The following is a description of a gene set: species: Homo sapiens Tarsal synostosis Human Gene Set: HP_TARSAL_SYNOSTOSIS Synostosis (bony fusion) involving one or more bones of the tarsus (calcaneus, talus, cuboid, navicular, cuneiiform bones)., and this is the list of marker genes: TBX4, FGFR2, LMBR1, FLNA, TNNT3, MYH3, FBLN1, TPM2, BMPR1B, MAP3K7, GDF6, FGFR1, NALCN, GDF5 (growth differentiation factor 5), POR, NOG (NCBI Gene Id 9241), GLI3, FGFR3, ATP7A, CHSY1 (chondroitin sulfate synthase 1), TNNI2, OFD1, MKKS, RNU12, FLNB, SMOC1